The following is a description of a gene set: Human Gene Set: HP_ABNORMAL_FINGER_MORPHOLOGY studied in species Homo sapiens An anomaly of a finger. Abnormal finger morphology, and this is the list of marker genes: SEC24C, ADH5, PRDM5, BMPR1A, CCDC88A, KAT8, B9D1, NLRP3, TGFB3, AHDC1, PHIP, WAC, EBP, NEFL (neurofilament light chain), H4C3, PIGF, ATP2B1, SP7, TMEM70 (NCBI Gene Id 54968), CHST11, CYP26B1, TMEM107, ZNF423, TMEM138, PIGL, AMMECR1, SMARCC2, DNMT3A, RMRP, KDR, AP4M1, ATL3, PSMC3IP, CCNK, CEP41, GABRD, HEATR3, RPS7, RPL27, DYNLT2B, RPL26, FGFR1, PRDM16, SMS (NCBI Gene Id 6735), NGLY1, FKBP6, MBD5, PNPLA6, WDR11, FLT4, NARS1, CHD7, CHD1, SMAD3, KIF22, ADNP, HOXD13, ADAMTS17, PRKDC (protein kinase, DNA-activated, catalytic subunit), ELN, DDR2 (NCBI Gene Id 4921), GPR101, IGHMBP2, SFTPA2, PTF1A, MACROH2A1, TRIM8, SOX11, IRX5, PIGS, ACTA1, SLC9A7, PUF60, MET, PRR12, SVBP, OBSL1, CDC42, LMNB2, FGF10, FANCG, CPLANE1, TMEM237, HS2ST1, CBL, PLXND1, DOCK6, HIRA, FAT4, CIITA, TGFBR2, ROR2, PCGF2, COL12A1, OGT, FCGR2A, COL25A1, PTHLH, CHRNA7, NKX2-5, DLG4, CLCN7, PIGV, PRKCZ, MYL11, NAA10, CAPRIN1, FGF16, RLIM, NAA80, PLOD3, CWC27, GGCX, SOST, ASPN, AGO2, GNPNAT1, PIK3C2A, WNK1, DNA2, COX4I1, IGF1R, LONP1, PIGY, USP7, ALDH1A2, WNT5A, KCNJ2, POLA1, SLC12A6, RAB3GAP1, SF3B2, H4C9, ERI1, IFT57, LZTFL1, LETM1, WDR73, GRB10, MAFB, DLL3, SPEG, FSHR, CCNQ, UNC80, POLR3GL, MAN2C1, RBM8A, TPM2, BMP15, FANCB, SMPD4, HYOU1, TBL1XR1, FBXO11, TAPT1, PPP2R3C, FANCM, CCDC28B, FAM13A, TRIM32, CRELD1, TFE3, EFL1, GDAP1, FIBP, ATR, PAX1, CTU2, ERCC1, ANKLE2, PGAP3, MASP1, BUB1, SCAPER, RFC2, PRKAR1B, CIBAR1, RRAS2, RAI1, BRCA2, TFAP2B, CUL3, PDE4D, ASAH1, EVC, EOGT, EFNB1, FGFR2, RAD51C, MAPK8IP3, STUB1, SPIDR, ARID2, FBXW11, TMEM218, HUWE1, THSD4, POLR1A, NPR3, BUD23, FBN1, CDC45, NRAS, NCKAP1L, RNU4ATAC, MAN1B1, SIL1, TUBB, EIF4A3, CBY1, CIC, GATAD2B, HOXA11, COL11A2, TTN, GLI2, CHD4, CHN1, CRPPA, KDM5A, PIGN, G6PC3, C2CD3, ARSL, UBAP2L, DVL3, RFX7, ASCC3 (activating signal cointegrator 1 complex subunit 3), CNOT1, ESAM, RNF13, EXOSC9, SMARCA4, VAC14, TTC21B, NCF1, PMM2, ZDHHC9, IHH, WNK3, APC2, GABRA3, CDT1, PIGO, GJB3 (NCBI Gene Id 91028), TRPS1, MMP23B, VPS37D, KLHL41, IQCE, WDR26, RB1, MYLK, GNPTAB, PAK3, SLC35B2, RPGRIP1, KATNIP, HESX1, SVIL, ORC4, NALCN, RPL11, BBS10, PACS2, BMP4, OPA3, EPS15L1, ERCC6, SCN2A, GPC3, MUSK (NCBI Gene Id 4593), TOPORS, DPH2, BCOR, ABCA3, MBTPS2, H19, MGP, SMO, FBLN5, PIGB, SACS, WDR4, KDSR, COL6A2, WASF1, CLP1, SMARCE1, CD96, NOD2, SHOX, FRAS1, SCN9A, COMT, COL10A1, SCN4A, SPART, NSDHL, TBX5 (T-box transcription factor 5), FLNB, CFTR, GATA2, WLS, PAFAH1B1, PTPN11, ZNF141, DYM, RTEL1, ATG7, TFAP2A, KIF1A, NPR2 (natriuretic peptide receptor 2), ATAD1, TNNI2, MRPS28, DDX11, BMPR1B, IARS1, PROP1, ALG9, RAPSN, MEG3, MTHFS, NR4A2, ITGA7, OTUD5, COASY (Coenzyme A synthase), FANCE, MRAS, DPYSL5, PRKG1, KCTD1, LAGE3, EBF3, NUP133, BMP1, H3-3A, PIK3R2, IFT122, ARL13B, EIF2S3, KIF7, GATA4, SLC25A46 (solute carrier family 25 member 46), BRAF, CSPP1, GORAB, FANCA, TRMT10A, DPF2, LIG4, KCNK4, GNB2 (NCBI Gene Id 96628), CDH11 (NCBI Gene Id 1009), PRKG2, SYNE1, MTX2, ADAT3, CHSY1, SMARCA2 (NCBI Gene Id 95083), TP63, DNAJC30, NEUROD2, ALG14, EFTUD2, FGFR3, RPL35A, KRT16, MKKS, RAB3GAP2, SPTAN1, CLCN3, IGF1, GNAS, EP300, NKAP, DHCR7, SIM1, YRDC, KMT2A, VPS35L, MOGS, UBE3A, TP53RK, ASXL3, COL11A1, RPL18, MSH4, GNAO1, SLC2A10, B3GLCT, CTSC, FOXP2, PPOX, ZNF469, TGDS, PTH1R, SHMT2, SCLT1, KIAA0586, GJA1, SALL1 (spalt like transcription factor 1), MUC5B, TNNT3, STAMBP, FANCL, RIT1, FANCC, RUSC2, TOR1A, POLR3A, ROBO1, ARMC9, EIF2AK4, GNPTG, LUZP1 (NCBI Gene Id 7798), ALG3, ECE1, GATA5, ZBTB20, PPP2R1A, SOS2, ASXL1, ORC1, PIGH, PORCN, ERF, RPS15A, MSL3, KCNJ11, NFKBIL1, ATP13A2, WDR19, SFTPC (NCBI Gene Id 6440), FOXP1, ARID1B, NUP107, NOG, RPS26, PIGA, ACVR1, PHF8, SNORD115-1, COL6A3, MEGF10, MED25, MECOM, KDM6A, PTPN22, RNU4-2, KCNJ8, SLC22A4, IDH1, ZNF699, BANF1, LRBA, KIF21A, TPM3, P4HTM, PTDSS1, MKRN3, EZH2, IQSEC2, CEP152, REV3L, ATP6V1B2, BBS2, SOX4, LMX1B, NKX2-6, CEP19 (centrosomal protein 19), EXOSC5, NEXMIF, GP1BB, SLC4A10, TRPV4, PRKACB, BLTP1, BAP1, MYMK, DPYS, HHAT, ATRX, BPNT2, MFAP5, HMGA2, ANO5, ZNF668, FANCF (FA complementation group F), HNRNPH1, GTF2IRD2, H3-3B, IFT74, HACD1, ZFPM2, COG7, RNF216, TMEM270, TCTN3, ARX, EIF4H (eukaryotic translation initiation factor 4H), BBS4 (Bardet-Biedl syndrome 4), CLIP2, KLF13, KLHL40, TBX1, LFNG, CCDC32, PTEN, SMC1A, DYNC2LI1, EED (NCBI Gene Id 8726), POC1A, UBR1, PIGG, RAC1, MEF2C, PYCR2, EMC1, PIGW (phosphatidylinositol glycan anchor biosynthesis class W), FTSJ1, ACTL6B, CANT1, COPB1, ACTG2, GDF1, HINT1, TAF4, RAB23, TOR1AIP1, MITF, MED12, TELO2, PAPPA2, JMJD1C, KCNN3, CEP104, HYAL1, YY1AP1, SUPT16H (NCBI Gene Id 6831), WDR35, PTRH2, SRCAP, SH2B1, ADAMTS10, CD244, DHODH, AUTS2, TBCK, TBL2, KIAA0825, DLK1, TMEM94, AIFM1, SIK1, PRIM1, PAX3, WIPI2, KCNA1, C1R, HSPG2, DEAF1, SUZ12, IKBKG, MESP2, CSGALNACT1, TBC1D2B, SMAD4, CCBE1, ALG13, CLIC2, SCN1B, PDPN, COG4, ZEB2, POR, RREB1, KMT2D, BIN1, GABBR1, PHF21A, SLC35C1 (NCBI Gene Id 55343), ALX3, LMBR1, SPTBN1, GMNN, CD55, BBS5, FLII, SLC35A3, KDM5C, PWAR1, BRAT1, CTDP1, NR2F1, DLL4, FBXO28, ALDH18A1, RPL35, BBS7, TONSL, INPP5E, IFT80, SIK3 (NCBI Gene Id 80236), RIGI, ERCC5 (NCBI Gene Id 2073), NSUN2, GLI1, PRG4, FRA10AC1, CTSK, TRIP13, SLC35A2, CRIPT, HEY2, GNAI1, CASK, CEP55, GJB6, RSPO2, RPL8, SIN3A, LMOD3, LMNA, HIVEP2, COL27A1, TGFB1, TCTN2, CCDC8, COL3A1, CHD6, RAF1 (NCBI Gene Id 5894), NSD1, DYNC2I2, PRKD1, IFT56, PEX1, FTO, POLR3H, BCR, ALX1, DHPS, IFT52, ACP5, ORC6, SATB2, DPAGT1, SPEN, SLC5A6, COL6A1, ANTXR2, RIPPLY2, GJB4 (NCBI Gene Id 2708), BMP2, ARL6 (NCBI Gene Id 84100), DVL1, L1CAM, MAP3K7, BRIP1, PSMB4, TRAF7, TRIP11, SKI, EFEMP2, TRPM3, BPTF, IDUA, IARS2, ARID1A, TRIO, OTUD6B, AMER1 (APC membrane recruitment protein 1), EXT2, ARVCF, LARS1, DSP (NCBI Gene Id 202512), SF3B4, TDO2, RPL31, KMT2C (NCBI Gene Id 80260), PWRN1 (NCBI Gene Id 791114), YY1, METTL27, CREBBP (CREB binding protein), NFIX, KPTN, SLC25A22, SLC18A3 (NCBI Gene Id 6572), B3GALT6, SMC3, RFT1, RYR3, TGFBR1, EIF2AK3, AKT3, RPS6KA3, PPIB, ZMYM2, SDCCAG8, PLAA, RPL15, DPP9 (NCBI Gene Id 91039), EN1, EXTL3, ADAMTSL1, TWIST1, RPS10 (ribosomal protein S10), ACTG1, RETREG1, RPL10, RBM10, ABL1, MYL2, CHD8, DSE, COL1A2, NONO, SMOC1, SPECC1L, MAT2A, RPS29, RASA2, INPPL1, EXOSC2, KIF15, HOXA13, NSD2, NIN, ZSWIM6, CITED2, PNKP, TTC8, AIP, TMEM147, TMEM216, FGF9, XYLT1, BRD4, NEB, SNIP1, IL21, QRICH1, CC2D2A, SOX9, GTF2I, AKT1, TPR, LTBP2, CTNNB1, PIEZO2, UBE4B, LAS1L, SMAD2 (SMAD family member 2), KCNE5, TBC1D24, SEM1, ALG6, MAGEL2, ARPC4, DDX59, HPGD, NAA20 (N-alpha-acetyltransferase 20, NatB catalytic subunit), SLC26A2, SPRED2, TRAIP, CPT2 (carnitine palmitoyltransferase 2), MYH3, OCRL, KIFBP, DOCK3, PTCH2, PAICS, PEPD, ADAMTS3, DYNC2H1, MADD, OFD1, PRKAR1A, DYRK1A, XYLT2, ADAMTSL2, SLC25A12, TBX22, CTCF, PSMD12, ERCC4, SLC32A1, MORC2 (NCBI Gene Id 22880), WNT7A, CUL7, DONSON, DYNC2I1, TCF4, DACT1, MAD2L2, FARSA, FLI1 (NCBI Gene Id 2313), HIC1, TUBB3, XRCC2, CCND2, FZD2, MIR140, RBBP8, RAD21, TAF6, PIK3CA, WDPCP, CHRNA1, ZNF462, TWIST2, KDM5B, GDF5, BICRA, RTL1, SC5D, RPL9, BTRC, ZNF407, UPF3B, MAF, HBB, KRT9, CRLF1, IFITM5, PLAG1, GATA1, AP1G1, APC, PIK3CD, TLL1, TBX15, CHRNG, KATNB1 (NCBI Gene Id 10300), RPGRIP1L, UBA2, ACBD6, FANCI, PIGQ, PHGDH, SPOP (speckle type BTB/POZ protein), MAPK1, SETD5, EPB41L1, CHRND, ACTA2, CDC42BPB, NIPBL, LTBP1, ZMIZ1, IFT172, SLC39A13, FBXW4, INTU, FGFRL1, ESCO2, ZFX, VPS13B, PYROXD1, CEP290, PPP1R21, STAG2, PARN, PEX5, DOK7, CPLX1, NOTCH2, RTTN (rotatin), SON (NCBI Gene Id 84155), TRAPPC9, PDE3A, CYP27A1, PCYT1A, SNRPN, ACOX1, ANKRD11, SCARF2, RPS27, ADGRG6, BBS1, KMT2E (lysine methyltransferase 2E (inactive)), DPH5, RUNX2, NEK9, PUM1 (pumilio RNA binding family member 1), PRKACA, KMT2B, FBN2, GJA8, TRRAP, PDGFRB, LEMD3, MIA3, CCDC47, NFASC, COL2A1, PPP1R15B, ASPH, NEDD4L, CFAP418, PKDCC, MAP1B, DNAJC21, GRIN1, LZTR1, SLC29A3, KCNH1, TXNDC15, RELN, NEK1, STK11, COL5A1, RPS28, RAB18, MIR17HG, JUP, NUP88, BLM, LHX3, ALMS1, MYH11, PCDHGC4, SAMD9, GLI3, TMEM67, TUBB2B, MEGF8, IFT27, XRCC4, ZC4H2, SOX6, TBX2, CNOT2, PHOX2A, DLX5, FLVCR1, MTM1 (NCBI Gene Id 4534), MYCN, JAG1, POGZ, ATRIP, WNT10B, LOX (lysyl oxidase), IDS, BGN, RPS19, IFT43, NELFA, RYR1, SH3PXD2B, FIG4, DMXL2, TGFB2, KAT6B, MRPS22, ACSL4, COL5A2, LBR, CWF19L1, SLC34A2, SLX4, TLK2, BNC1, MMP2, EDA, BHLHA9, SALL4, AHI1, KCNAB2, NLRP1, KDM4B, HECTD4, NHS, CENPE, DLX6, ERCC2, FN1, RECQL, RPS24, BRCA1, TMEM231, NEPRO, GPC4, ANAPC1, PIGP, RPS23, PLOD1, SFTPA1, PTCH1 (NCBI Gene Id 8015), LIFR, MAX, SHANK3, KRT14, BCORL1, NOTCH1, MKS1, STAG1, CHUK, RECQL4, SUMF1, FOXE3, IFT140 (intraflagellar transport 140), ACTB, KNSTRN, HYLS1, EDA2R, NPHP1, IPO8, PIBF1, LIMK1, PHF6, SETD1B (SET domain containing 1B, histone lysine methyltransferase), CILK1, RAB11B, RFWD3, LAMA5, DDX6 (DEAD-box helicase 6), SLCO2A1, BBS9, EVC2, ALX4, PEX6, MYH8, LAMB3, STX1A, CNOT3, RAB33B, LRP4, PDE6D, IGF2, WASHC5, HNRNPH2, ZNF292, PIK3R1, ARHGAP31, CASZ1, CDKL5 (NCBI Gene Id 6792), KDM1A, FLNA, CBS, UFD1, ATP11A, SELENON, KANSL1, AFF2, GPX4, MAPRE2 (NCBI Gene Id 51683), NKX3-2, ABCA12, TBR1, KDM6B, SLC25A24, MGAT2, ARHGEF2, NDE1, HNRNPR, B4GALT7, NR5A1 (nuclear receptor subfamily 5 group A member 1), TCTN1, ADAMTS2, DLX3, NUP37, HRAS, ARL3, SPRED1, PLK4, COG1, NARS2, RIPK4, KAT6A, MSX2, GRM7, BUB1B, YWHAE, PCNT, GNB1, ERCC8, SIAH1, EIF4A2, CAPN3, BBIP1, MLXIPL, RPS20, MAP3K20, CEP57, MCTP2, COL1A1, SMARCAD1, GLDN, PSMB8, COG5, CCDC22, UBE3B, TCF20, MEIS2, LAMC2, CNTN1, TRAPPC2, TBX3, ZIC3, H4C5, PALB2, IFIH1, ALOX12B, CHST14, PRMT7, SUFU, KRT1, ADAMTS15, PAH, EXT1, UBA1, BICD2, HDAC8, TOGARAM1 (TOG array regulator of axonemal microtubules 1), IL11RA, HEPACAM, HERC2, RPL5, ATN1, GTF2IRD1, ALG12 (NCBI Gene Id 79087), CCN6 (NCBI Gene Id 8838), RPS17, BUB3, MATN3, SOS1, LAMA3, DHX30, CDC6, SCNM1, NPAP1 (nuclear pore associated protein 1), TMCO1, MECP2, TERT, KIAA0753, MYMX, TERC, CTBP1, COG8, COMP, STN1, SEMA3E, ZMPSTE24, ACAN, EMG1, SNRPB, RAB34, FANCD2, IL10, HNRNPK, CEP120, RAD51, UBE2T, MTR, PACS1 (NCBI Gene Id 55690), RSPRY1, RBPJ, WFS1, SLC9A6, SHH (NCBI Gene Id 6469), KCNK9 (potassium two pore domain channel subfamily K member 9), GJA5, PITX1, CBFB, LHX4, ZNHIT3, B9D2, CLCF1, TBX4, CDKN1C, TSR2, MYBPC1, FAM149B1, GPKOW, HDAC4, SMARCD1, GON7, SETBP1, HERC1, PROKR2, EHMT1, ECEL1, FGD1, SMG9, FILIP1, USP9X, TUBA1A, POU1F1, GATA6, MYOD1, ABCC8, BBS12, CKAP2L, BRF1, NUP85, CHST3, SBDS, OSGEP, ADA2, PI4KA, ZSWIM7, SOX5, B3GAT3, JARID2, MTOR, MAP2K1, MED12L, HES7, BAZ1B, AEBP1, FERMT1, CSNK2A1, EFEMP1 (NCBI Gene Id 399564), ALOXE3, PGAP2, KRAS, FKTN, SMARCB1, DNM1L, RRAS (NCBI Gene Id 6237), ABCC9, TPRKB, CUL4B, EXOC6B, RERE, SNORD116-1, RASGRP1, NXN, ODC1, CRKL, PQBP1